The following is a description of a gene set: Mouse Gene Set: GOBP_NEGATIVE_REGULATION_OF_BONE_REMODELING studied in species Mus musculus Any process that stops, prevents, or reduces the frequency, rate or extent of bone remodeling., and this is the list of marker genes: Gpr137, Vegfa, P2rx7, Hamp, Ubash3b, Cartpt, Sfrp1, Fshr, Cldn18, Grem1, Tmem119, Il6, Cyp19a1, Csk (NCBI Gene Id 12988), Gpr137b, Inpp5d, Tnfrsf11b (tumor necrosis factor receptor superfamily, member 11b (osteoprotegerin)), Ceacam1, Cd38, Iapp